Given this list of marker genes 7a, 6, 9b, SARS coronavirus, complete genome, 8, here is a description of the gene set: Reactome Pathway: Translation of Accessory Proteins studied in species Homo sapiens Accessory proteins are encoded after the polymerase/replicase genes by mRNA6 (protein 6), mRNA7 (protein 7a), mRNA8 (protein 8), and bicistronic mRNA9b (protein 9b). These proteins are not essential for viral replication and assembly in vitro, but likely influence the pathogenesis of the SARS-CoV-2, like the accessory ORFs of other coronaviruses. part of: Late SARS-CoV-2 Infection Events